The following is a description of a gene set: Any abnormality of the large intestine. species: Homo sapiens Abnormal large intestine morphology Human Gene Set: HP_ABNORMAL_LARGE_INTESTINE_MORPHOLOGY, and this is the list of marker genes: ARL3 (ADP ribosylation factor like GTPase 3), SALL4, KIAA0586, RTEL1, PIK3CG, SDCCAG8, RFC2, ZFX, ADA2, MSH6, TYMP (NCBI Gene Id 4334), BBS4, DDB1, CCND1, FERMT1, BAZ1B, HYLS1, MKS1, RPL26, TRIP13, TMEM67, PLA2G2A, FANCB (NCBI Gene Id 2187), BBS10, SUFU, SLC6A14, TTC7A, BBS5, RPS26, FANCM, TCOF1, TCF4, PRMT7, FREM1, EDNRA, RPL27, ZMPSTE24, GREM1, PRKAR1A, GPIHBP1, MYH11, TMEM237, RAD51C, RPL11, IFT74, CEP290, TP53, ZEB2, EP300, CASP10, CFAP418, CEP19, MLXIPL, NCF1, PHOX2B, STXBP2, FH, EPCAM, MSH2, PALB2, KEAP1, DCTN4, CARD11, DDX59, ERCC4, RPS19, FAS, RPS20, SKIC2, AHI1, FANCD2, TMEM216, NDUFB11, NPHP1, PERCC1, NCF4, CEP41, KITLG, PIK3CD, PSMB10, ZAP70, SDHC, IFT172, ECE1, LONP1, IVNS1ABP, TUBA1A (tubulin alpha 1a), LBX1, PRF1, CBY1, MCC, FANCF, CEP120, BUB1B, RPGRIP1L, PTPRJ, L1CAM, RAD54B, RABL3, SLC26A9, BBS7, KRAS, RPL35, CCDC28B, DOCK2, JAK3, ERBB2, IL21, CIITA, TMEM218, RPS15A (ribosomal protein S15a), PIGL, KIAA0753, FANCI, HLA-B, HMOX1, WDPCP, F13A1, POLE, UBR1, VPS37D, FANCC, JAK1, EFEMP1, ENG, MDM2, FOXE1, B9D2, MAD1L1 (mitotic arrest deficient 1 like 1), TCTN1, COL5A1, XRCC2, BLM, KATNIP, IFT27, DCLRE1B, SETBP1, MBTPS2, CC2D2A, FLNB, NRTN, MIF, LYN, GCLC, OFD1 (OFD1 centriole and centriolar satellite protein), SDHD, NSUN2, MID1, FANCG, OTUD5, EIF4H, FANCL, HFE (NCBI Gene Id 3077), NF1, KIF7, TSR2, PIGN (NCBI Gene Id 23556), ABCD1, BUB1, HLA-DRB1, XIAP, SALL1, CHEK2, AKT1, SLC37A4, COL14A1, PIBF1, TYR, POLD1 (DNA polymerase delta 1, catalytic subunit), UNC13D, MAP3K7, SDHB, FXN, NTHL1, BCL10, TBL2, BRCA1, SLC9A3, DOCK8, RPL9, SEC23B, LRBA, BMPR1A, SEMA3C, ARVCF, B9D1, MBD4, IRGM, SYK, SLX4, SPINT2, ABCB1 (ATP binding cassette subfamily B member 1), SEMA4A, BBS2 (Bardet-Biedl syndrome 2), STAT1, HEPACAM, SMO, NLRC4, FOXF1, ATM, ELANE, GDNF, RPS24, CYBC1, PSTPIP1, PIGW, DKC1, ARL6, FREM2, ARX, EDN3, MINPP1, IKBKG (NCBI Gene Id 8517), FGFR3, CFTR, EDNRB (NCBI Gene Id 3282), KIT, STK11, SERPINA1 (NCBI Gene Id 5265), ARMC9, BBS1, BUB3, PMS1, RPL18, CARMIL2, HPS1, RPL31, MEFV, POLR1D, KCNN4, ERBB3, PIGV (phosphatidylinositol glycan anchor biosynthesis class V), TTC8, FLCN, MST1, PIGO, STX11, TOGARAM1, INSR, GSTM3, ATRX, NRAS, CEACAM6, DHCR7 (7-dehydrocholesterol reductase), RAD51, DDX3X, RPL35A, PGAP3, PGAP2, HABP2 (NCBI Gene Id 3026), FANCE, SH2B1, SREBF1 (NCBI Gene Id 6720), PDE6D (NCBI Gene Id 5147), DLC1, ELF4, BRCA2, PDGFRA, RHBDF2, SRC, MLH1, SRP68, METTL27, DYM, RPS6KA3, PMS2, CEP57, MITF, PLCG2, AAGAB, CTNNB1, ACADVL, SOX10, CDK8, RMRP, CARD8, HCCS (holocytochrome c synthase), RPL5, IGHM, PTEN, TCTN2, RBCK1, STX1A, HIRA, TLR2, BUD23, VANGL1, INPP5E, LTBP4, NSD1, UBE2T, DEF6, ACTG2, COG6, SLC11A1, SEMA4D, MYO1H, LIMK1, ATP7A, F13B (NCBI Gene Id 2165), NOP10, CCBE1, MAD2L2, SF3B4, SCAPER, WIPF1, MSH3 (mutS homolog 3), RAC2, PDGFRL, TGFBR2, FCHO1, BACH2, USF3 (NCBI Gene Id 205717), CYBA, PKD1, CCNQ, CSPP1, LIG4, TMEM270, RPS28, FKBP6, TMEM231, RPS10, COX7B, TGFB1, PTPN6, SHARPIN, PIK3CA, GATA6, RIPK1, BAX, TRIM32, SNAI2, POLG, LZTFL1, SCLT1, DOCK11, PIGY, LMOD1, GP1BB, PAX3, SDHA, COMT, POLR1C, NOD2, INAVA, TFAP2A (NCBI Gene Id 95131), KIFBP, CHD8, KLLN, MED12, CPLANE1 (NCBI Gene Id 84157), FANCA, MASP2, BRAF, RET, SKIC3, IL10RB, IL6, CEP104, LMNA, BRIP1, RNU12, UFD1, GTF2IRD1, FCGR2A, AURKA, PTPN12, AP1S1 (adaptor related protein complex 1 subunit sigma 1), ARPC1B (NCBI Gene Id 10095), MKKS, RPS17, RFWD3, GTF2I, NAA10, SEC24C, BBIP1, RREB1, DICER1, APC2, POLR1B, DCC, DNAJC30, IL10RA, RPL15, TBX1 (T-box transcription factor 1), CDKN2A, RPS29, NIPBL, RPL8, C1S, MNX1, SLC6A8, RPS7, BDNF, ELN, PI4KA, PALLD, NCF2, MYLK, TCTN3, ARL13B, BBS9, COL1A1, RPS27, FOXP3, OPLAH, CEACAM3, SMAD7, TNFAIP3, GATA1, AXIN2, GUCY2C, PDE11A, HEATR3, RECQL4, MUTYH, APC, CYBB, ITGB2, IL37, GTF2IRD2, NFKBIA, COL5A2, JMJD1C, TMEM138, BBS12, FCN3, FASLG, BCOR, MLH3, SMAD4, CTLA4, ASCL1, DACT1, POLA1, STAT3, GPR35, ZNF423, SEMA3D, CLCA4, CLIP2, WAS, RNF43 (ring finger protein 43)